Given this list of marker genes CLCN2, BMP6, CACNA1H, CYP11B2, WNT4, EDNRB, CYP21A2, SCNN1B, DKK3, CYP11B1, BMP2 (bone morphogenetic protein 2), BMP5, DAB2, REST, here is a description of the gene set: The chemical reactions and pathways involving mineralocorticoids, hormonal C21 corticosteroids synthesized from cholesterol. Mineralocorticoids act primarily on water and electrolyte balance. Human Gene Set: GOBP_MINERALOCORTICOID_METABOLIC_PROCESS species: Homo sapiens